Given this list of marker genes IFFO2, IDE, GPR132, BLOC1S1, BBS2, APOBEC2, CUEDC2, NFIX, ECM1, NEDD4, PDLIM1, TAGLN2, TIMM8B, NAT9, MAP3K20, RHBDF2, CFAP68, MXD4, MTFMT, CXCL2, E2F2, TAF5, COBLL1, ACAA2, IP6K1 (NCBI Gene Id 9807), TIMP2, SETX, SCARB2, VEZT, ATG101, ABHD12, NR4A2, PLEKHA7, LMNA, ZSWIM8, GIT1, ZNF282, PAQR4, HS6ST1, PXDC1, RELL1, LRRC45, GPX1, BTG2, ARL16, ATG16L2, MGRN1, LPL, PREPL, PGM1, TBCB, SH3KBP1, NUDT14, CARD11, PGAP1, ZFP82, PBXIP1, DGLUCY, MOB3A, SLC25A30, PAFAH1B3, HGSNAT, C1orf131, EHBP1, PHLPP1, DGKE, STRN, NCK2, SLC2A6, PGPEP1, LTB, PIK3R1, TMEM43, GPX7, ATM, MYADM, MSL1, TCEANC2, MGST2, SBNO2, BCL10, BAG4, CCND2, PLEKHO2, HMBS, APLF, RHOG, CD2, ACKR2, RBM33, DYNLRB1, TNFRSF9 (NCBI Gene Id 3604), YES1, PMVK, CXCL13, PAFAH2, COMT, WHAMM, RFXANK, SELENOP, SAP30L, SMPDL3A, CCSER2 (NCBI Gene Id 54462), RAP2A, ENDOD1, DFFA, TTC4, UPF3B, PI4K2B, ADARB1, SEPTIN9, SWSAP1, IL6ST, LDLR, RAB11FIP1, CBFA2T3, ZMAT3, RRAD, KLF9, CHCHD10, PMP22, IRF6, TBC1D14, MYO7A, SPACA9, RAB32, PPL, FAM20B, GLUL (glutamate-ammonia ligase), DSTYK, KLF3, ZC3H12D, MRPL58, SPEN, MAPK11, BORCS7, PARD6G, YIPF1, RAPGEF1, CYB5A, B4GALNT1, CFH, HSPA4L, TRAF3IP2, HSD11B1, GPI, ANKH, OMA1, COA8, ZNF189 (zinc finger protein 189), GAS7, GLUD1, SFTPB, DHX40, MADD, CDC42SE1, TRIM7, MAP7D1, TUSC1, ACVR1B, SEL1L, ABR, IQGAP2, TGFB1, RTN4RL1, SLC41A1, IL17RA, RFC3, RCN3, PPCDC, NENF, SLC38A1, PIM2, PKP4, ZNF692, ACSS1, B3GNTL1, PARD3B, MGMT, LONP1, NINJ1, DENND6B (NCBI Gene Id 414918), TECR, TPD52L2, POP7, ITGA4, GPR171, GTF3A, NUPR1, ERP29, SPTBN1, ARFGEF2, TRAM2, NCOA7, SYNE2, MAPK14, IER2, TRAF4, LPCAT4, PIK3R5, here is a description of the gene set: Differentially expressed genes of CD11b+Gr-1+ immature myeloid cells (IMCs) in the bone marrow and colonic tumor setting of histidine decarboxylase (HDC)-KO mice were examined by microarray (Affymetrix Mouse 430.2 array). Myeloid differentiation-related candidate genes were sought to be isolated and functionally studied. studied in species Homo sapiens from publication Yang XD, Ai W, Asfaha S, Bhagat G, Friedman RA, Jin G, Park H, Shykind B, Diacovo TG, Falus A, Wang TC (PMID 21170045) Human Gene Set: GSE23502_BM_VS_COLON_TUMOR_HDC_KO_MYELOID_DERIVED_SUPPRESSOR_CELL_DN Genes down-regulated in myeloid-derived suppressor cells with HDC knockout: bone marrow versus colon tumor.